The following is a description of a gene set: species: Mus musculus Mouse Gene Set: MIR_302A_3P_MIR_302B_3P from publication Chen Y, Wang X (PMID 31504780) Genes predicted to be targets of miRBase v22 microRNA mmu_miR_302a_3p, mmu_miR_302b_3p in miRDB v6.0 with MirTarget v4 prediction scores > 80 (high confidence targets)., and this is the list of marker genes: Retreg3, Dpp8, Elk4, Cluh, Nfya, Dgkq, Marchf8, Zcchc24, Jazf1, Shc4, Zfp53, Rb1cc1, Tiam1, Nsd3, Irf2bp2, E2f2, Col17a1, Tgfbr2, Tiparp, Lrit1, Irf2, Ryr2, Cdk6, Ambn, Smarcc2, Npas3, Ago1, Ss18l1, Arhgef10, Kcnd2, Rest, Phc3, Tmub2 (transmembrane and ubiquitin-like domain containing 2), Olig2, Tmem72, Parp8, Sf3b1, Slf1, Cpeb1, Miga2, Rnf216, Vmn1r45, Ppp1r3e (protein phosphatase 1, regulatory subunit 3E), Zbtb5, Reep3, Cdkn1a, Slc5a10, Ppp1r36 (protein phosphatase 1, regulatory subunit 36), Ikzf2, Unkl, Nufip2, Med12l, Kif26b, Epha2 (NCBI Gene Id 13836), Suco, Cfl2, Osmr, Myrf, Sdc1, Cd200, Zkscan1, Arid4a, Slc49a4, Fgf9, Asap1, Cyp26b1 (cytochrome P450, family 26, subfamily b, polypeptide 1), Uap1, Ccnd1, Tle4, Suv39h1, Rps6ka1, Arhgap29, Synpo2, Atxn1, Fam168b, Ash1l, Zbtb11, Mllt6, Pak5, Adam9 (NCBI Gene Id 11502), Tnfaip1, Clptm1l, Ism2, Smc2, Zfp367, Rnf6, Ncoa7, Ptprb, Prdm4, Arhgef17, Snx8, Rab22a, Ect2, Coro2b, Rab8b, Rab5c, Ube2b, F3, Zfp827, Asf1b, Prdm8, Sowahc (NCBI Gene Id 70860), Hlf, Slc6a9, Erc1, Asf1a, Nfia, Zbtb43, Hif1an, Arnt2, Flt1 (FMS-like tyrosine kinase 1), Tapt1, Epha5, Nhsl3, Trpv6, Myo5a (NCBI Gene Id 57374, myosin VA), Pip4k2a, Spop, Gm5622, Tnrc18, Fgd4, 2410002F23Rik, Syde1, Rgmb, Fndc3a, Slc30a10, Tmem35b, Ccnj, Map3k14, Mtus1, Lrat, Plagl2, Akr1c21, Glis3, Fzd3, C87436, App, Ube2q2, Znrf3, Rtn1, Zfp148, Sar1b (secretion associated Ras related GTPase 1B), Skida1, Erap1, Cdca7, Malt1, Kat2b, Vldlr, Bcl11b, Pde3b, Pak2, Ednrb, Dcdc2a, Rock2, Mospd2, Pbx3, Zfyve26, Myocd, Tmem123, Kmt2a, Kpna2, Ak2, Mtmr3, Aak1, Rictor, Tfap4, Mink1 (misshapen-like kinase 1 (zebrafish)), Ddhd1, Dcp1b, Rnf150, Gpc6, Cnot6, Glod4, Prrg1, Elavl2 (NCBI Gene Id 15569), Usp24, Armc8, Ythdf3, Slc22a23, E2f5, Nr2c1, Ankrd17, Caprin2, Ddias, Marchf11, Mylk, Dcaf6, Gpr158, Asxl3, Twf1, Lefty2, Mettl21c, Nr2c2, Taf1, Mpc1, Fgd5, Mier3, Lhx8, Rassf2, Irf9, Tet1, Kcnb1, Ssr1, Bloc1s5, Itgb8, Mtf1, Slc7a2, Clock, Golga1, Srcin1, Hmbox1, Kmt5b, Rab11a, Pou6f1, Zfp800, Nfib, Mycn, R3hdm1, Crot, Hs2st1, Bcl6, Kdm1b, Lats2, Yod1, Hipk3, Unc80, Cnot6l, Wdr48, Prdm16, Btg1, Atf6b, Txnip, Rbl2, Zfp9, Arid4b, Lgr4, Lefty1, Macc1, Zbtb41, Ezh1, Wdr1, Rbl1 (NCBI Gene Id 99395), Crim1, Pcdh7, Trip11, Kremen1, Lhx6 (LIM homeobox protein 6), Trim36, Krt222, E2f7, Zfp362, Tmtc1, Unk, Tox, Cxadr, Ptpn21 (protein tyrosine phosphatase, non-receptor type 21), Map3k2, Rsbn1, Dcun1d4, Micu1